Given this list of marker genes POLR1HASP, GCM1, IFNA1, TSSK2, EHHADH, CPB2, RB1CC1, GPR18, CHRNB4, PRPS1L1, SLC6A4, MSH3, GHRHR, MLLT10, STARD5, SLC33A1, RREB1, DDX52, UBE4B, R3HCC1L, OR10H3, CALN1, ATP8B1, KRR1, SUPT3H, ABCB10, ATP2B2, ELAVL2, SOAT2, SPA17, DNAJC16, SGCD, LDB3, ERC2-IT1, FGF18, TLE1, GRIK1, PSD, F2RL1, TRIM24 (NCBI Gene Id 8805), GCA, FRY, SIX6, COLGALT2, CCN6, IL11RA, PSG1, PLA2R1, ITGBL1, CDC42BPA, ELOVL6, CXCL5 (NCBI Gene Id 6374), GLRA3, MC5R, BIRC5 (NCBI Gene Id 332), BRINP3, CTSB, AMMECR1, TLL1, HOXB7, CPEB3, DMPK (DM1 protein kinase), TRIO, MAGI1, TBX19, NXPH2, COL19A1, GUCY2C, DNAJC22, TACC2, PIK3C2A, EDIL3, COQ7, MSL3, NHEJ1, ZBTB33, MPP3, ZBTB40, GPR171, CDH8, HOXC11, NR3C2, CNTN6, IL4, MASP2, NOL4, SLC17A3, SERPINA4, PHF10, RORB, CMKLR2, WBP4 (WW domain binding protein 4), CHST1, PAXIP1, MAGEA8, SRPK3, C6, TNK1, CADM4, GYS2, FUT1, ATP6V0A2, GNG4, F2RL3, PRKCA, GABRB2 (gamma-aminobutyric acid type A receptor subunit beta2, NCBI Gene Id 2561), IGKV7-3, ZNF202 (zinc finger protein 202), GUCY2F, ADAMTS3, HEPH, HSPA1L, PTPRR, STAC, NPFF, IFNA2, BRWD1, ZNF134, MDM2, LPAR4, SLC16A5, DBT, SPRR2C (small proline rich protein 2C (pseudogene)), CTRL, PHLDB1, TMEM26, SPATA2, ZBTB14, FZD5 (frizzled class receptor 5), KLRC4, IFNA8, ABO, KRT83, BRCA1, SLC6A2, SULT4A1, NEB, STAG1, ISL1, S100A5, EPHB2, P2RY10, KPNA1, RGS7, SLC4A8, PLEKHB1, MAGEA9, FAM13A, SEMA6A (NCBI Gene Id 57556), LILRA1, MFN1, PLPPR4, NTNG2 (netrin G2), DRC3, ITIH3, LORICRIN, ATP4B, KRT86, MYH2, USP46, NOS2 (nitric oxide synthase 2), SIM2, IPO9, CDR1, JRKL, ST8SIA1, SLC46A3, NR1I2, SMYD3, LRP4, ANXA10 (NCBI Gene Id 51436), B4GALT6, DMD, HCRTR2, CYP11A1, PCDHB17P, BCL2L11, IL13RA1, CFH (complement factor H), DEPDC5, BMP10 (NCBI Gene Id 27302), ARL3, MON2, FAS, PCM1, GPR15, MPZL1, RBBP7, C1orf216, AOC4P, PDE6A, PTPRB, ERCC4, JADE3, RYR3, NFX1, EXOC4, IFNW1, OR2B6, LINC03124, PPP1R12B, TSPAN2, SLC15A1, RSC1A1, PTEN, RBMXL1, CDC73, AQP7, USP20, POLR3F, PLXNA3, FOSL1, TTTY1, HNF1A, CYP2E1, CDKL5, LGI1, MINDY2, BRD4, PTPN20, CLCN3, DAZL, COL8A1, HTR1E, AKAP3, TPD52L1, KCNA5, SCN7A, NXPE3, IFNA10, SLC14A1, ATF2, RAD51D, TSHB, HSD3B2, DGCR5, CACNA2D1, PRELID3A (PRELI domain containing 3A), PTPRS, PPP2R5B, POU6F1, RPS6KA5, CYP4F2, GPR19, ZNF33B, ZNF132, PVR, ZNF157, ZSCAN26, ADAMTSL3, MAP3K1, PGM3, ADCYAP1, POU6F2, RXRG (NCBI Gene Id 6258), KRT33A, FAM110B, ADRA1A, TNIK, TBXT, REPS2 (NCBI Gene Id 9185), FLRT2, CDH4, PAX7, RUNX2 (RUNX family transcription factor 2), ADAM22, IL16, H3C6, ZNF141, PART1, IL7, NPAS2, KRT2, KRT34, FBXL4, ABCC8, NFAT5, CYP2C19, MGA, SLC17A1, CRHR1, MAP2K6, CAMK4, CCL16, COL14A1, CCR3, POLR2K, ADAM20, MYT1, FSHR (follicle stimulating hormone receptor), FNTB, ATXN3, TENM4, TANC2, MAP2K7, PDE10A, FGA (fibrinogen alpha chain), IFNA14, FGF2 (NCBI Gene Id 2247), ATP10B, ROR2, GLE1, ULK2, PPM1E, BARX2, THPO, ARFGEF2, SYT5, LILRA4, EYA1, ADGRL2, COX6A2, PAX6, TFDP2, GJB5, SOCS6, LECT2, CEP162, MAP2, ABCB1, DRD1, ZNF266 (zinc finger protein 266), RNF24, KLHL23, NEDD4L, PHOX2B, CAMTA1, APOBEC1, SLC14A2, PDE4D, here is a description of the gene set: Neighborhood of ATF2 activating transcription factor 2 in the MORF expression compendium species: Homo sapiens Neighborhood of ATF2 Human Gene Set: MORF_ATF2